The following is a description of a gene set: studied in species Mus musculus Mouse Gene Set: GOBP_VASCULAR_ASSOCIATED_SMOOTH_MUSCLE_CELL_DEVELOPMENT The process aimed at the progression of a vascular smooth muscle cell over time, from initial commitment of the cell to a specific fate, to the fully functional differentiated cell. A vascular smooth muscle cell is a non-striated, elongated, spindle-shaped cell found lining the blood vessels., and this is the list of marker genes: Comp, Vegfa, Eng, Pbrm1, Sgcb, Hes1, Notch1, Ednra, Hey2, Adm, Efemp2 (epidermal growth factor-containing fibulin-like extracellular matrix protein 2), Nfatc4, Nfatc3, Ramp2, Smad6